Given this list of marker genes CD58, CDC42EP4, PYGL, CTSS, TYROBP, IFNGR2, ALDH1A1, CTSL (cathepsin L), CD33 (CD33 molecule), TSPAN14, SCPEP1, SERINC5, RHOB, S100A9, BCL2A1, NACC2, ALOX5, TKT, FTL, IRS2, TNFAIP2, LAT2, NOD2, TLE4, SLC2A3, CYP1B1, SERPINA1, HCK, CAST, MTMR11, AIF1, HLA-F (NCBI Gene Id 3134), LILRB3, EVI2B, CAPN2, PELI1, TIMP1, PADI2, HCAR3, ENTPD1, CD44, CFP, FGL2, PKM, MYO1F, ITPK1, FBXL5, GASK1B, LILRA2, BNIP3L, PTP4A2, QPCT, NAIP, C11orf21, CASP1, RNASE2, LILRA1, TSPO, CD93, ANXA1, SLA, AOAH, IER3, NLRP3, HBEGF, FCGR2C, CD163, KDM7A, ITGB2, GMFG, LY86, RAB32, ZDHHC7, IL15, LGALS3, PLA2G7, LYST, APLP2, IER2, EPB41L3, PTPRC, EGR1, TBXAS1, MARCKS, SLC6A6, PLBD1, TNFRSF1B, RAB31, SOD2, ARHGDIB, ASAH1, CLEC4A, RIN2, MBD2, NFIL3, CREG1, TLR4, CALML4, CD86, CHSY1, APOL3, NEAT1, GAPDH, BCL6, S100A12, CXCL8, BEST1, MAFB, RAB20, TREM1, LST1, CD14, UPP1, FBN2, HMOX1, TENT5A, NUP214, OAT, CDC42EP3, ALDH3A2, BST1, GBP2, WDFY3, MSN, FPR1, BLVRB, IFITM2, NLRP1, S100A10, CSF1R (NCBI Gene Id 8156), TLR2, SLCO3A1, MARCO, RNF19B, IRAK3, FYB1, FGR, HEBP1, HIF1A, ITM2B, C5AR1 (complement C5a receptor 1), CREB5 (NCBI Gene Id 9586), KLHL2, EFHD2, HK2, USP3, ARHGEF40, CRISPLD2, MEGF9, CSRP1, ITGAX, GSAP, PILRA, TNFSF12, UBE2D1, PTGS1, S100A4, PCSK5, NAMPT, CEBPA, ALDH3B1, SPI1, SLC7A7 (solute carrier family 7 member 7), PXN, S100A11, CLEC7A, LIN7A, BLVRA, P2RY13, SDCBP, SHFL, F5, CD1D, SLC31A2 (solute carrier family 31 member 2), KLF11, LINC00623, DPYD, TIMP2, CKAP4, ZFP36L1, CDC42SE1, HPSE, YBX3, IL1RN, TRIB1, G0S2, RCBTB2, RXRA, ACSL1, TCF7L2, NCF2, STS, APOBEC3A, CALM3, GAS7, SEC14L1, SIRPA, PPIF, DPEP2, here is a description of the gene set: from publication Nakaya HI, Wrammert J, Lee EK, Racioppi L, Marie-Kunze S, Haining WN, Means AR, Kasturi SP, Khan N, Li GM, McCausland M, Kanchan V, Kokko KE, Li S, Elbein R, Mehta AK, Aderem A, Subbarao K, Ahmed R, Pulendran B (PMID 21743478) species: Homo sapiens Systems vaccinology has emerged as an interdisciplinary field that combines systems wide measurements and network and predictive modeling applied to vaccinology. Here we used the systems vaccinology approach to study the molecular mechanisms underlying th Human Gene Set: GSE29618_MONOCYTE_VS_PDC_UP Genes up-regulated in comparison of monocytes versus plasmacytoid dendritic cells (pDC).